The following is a description of a gene set: Genes down-regulated in B lymphocytes: control versus CpG oligodeoxynucleotide 1826. species: Homo sapiens We have previously shown that rheumatoid factors (RF) produced by Fas-deficient autoimmune-prone mice typically bind autologous IgG2a with remarkably low affinity. Nevertheless, B cells representative of this RF population proliferate vigorously in response IgG2a/chromatin immune complexes through a mechanism dependent on the sequential engagement of the BCR and Toll-like receptor 9 (TLR9). To more precisely address the role of both receptors in this response, we analyzed the signaling pathways activated in AM14 B cells stimulated with these complexes. We found that the BCR not only serves to direct the chromatin complex to an internal compartment where it can engage TLR9 but also transmits a suboptimal signal that in combination with the signals emanating from TLR9 leads to NF-kappa-B activation and proliferation. Importantly, engagement of both receptors leads to the upregulation of a group of gene products, not induced by the BCR or TLR9 alone, that include IL-2. These data indicate that autoreactive B cells, stimulated by a combination of BCR and TLR9 ligands, acquire functional properties that may contribute to the activation of additional cells involved in the autoimmune disease process. from publication Busconi L, Bauer JW, Tumang JR, Laws A, Perkins-Mesires K, Tabor AS, Lau C, Corley RB, Rothstein TL, Lund FE, Behrens TW, Marshak-Rothstein A (PMID 18025183) Human Gene Set: GSE6674_UNSTIM_VS_CPG_STIM_BCELL_DN, and this is the list of marker genes: NDE1, IQCE, PHF5A, HIGD2A, BPGM, LMAN1, MPV17, SLC29A1 (solute carrier family 29 member 1 (Augustine blood group)), WBP1, LSS, NME3, ANKRD22 (ankyrin repeat domain 22), QSOX1, FHOD1, ACAD9, S1PR1, NUP37, BEST1, SUSD1, IMP3, MIR302A (microRNA 302a), LRRC45 (NCBI Gene Id 201255), HGSNAT, TRUB2, OLFM4, SLC22A4, FMNL1, CCDC14, SLC37A2, MMACHC, RBM44, PDE2A, ABCD1, SUSD3, HNRNPH1, NAV1, LMBR1, PCDHB18P, ACTR10, CTHRC1, EFL1, ARHGAP27, CGNL1, TALDO1 (NCBI Gene Id 6888), NDUFA12, YTHDF2, SLC4A1AP, HGF, NBEAL2, HSPB6, LSG1, LAT, DNAJC2 (DnaJ heat shock protein family (Hsp40) member C2), B3GNT2, CABYR, SLCO4A1, ANKRD26 (ankyrin repeat domain containing 26), HYCC1, CREG2, SLC48A1, GTF2H5, SFXN4, PRKCH, TMEM266 (NCBI Gene Id 123591), PAF1, POLR3F, UFD1, MOGAT2, INPP5J, AHR, ABT1, HABP4, ENTPD7, SSX2IP, CEP152, ABHD4, BTBD9, RNF128, NADSYN1, GRIPAP1, MEFV, RASGRP4 (RAS guanyl releasing protein 4), FTSJ1, DCUN1D3, KIT, SLC20A1, TOMM7, NUP107, DESI1, NCDN, MTFR1, NPPC, KCTD12, TRA2B, AGK, MRPL49, GPKOW, BACE1, FHL1, SHARPIN, PSMD4, ALDH9A1, MAF, PADI4, BGN, PDXK, IBTK, CBR1, OAS3, LGR4, PCGF2, MIR191, SLC25A35, SUOX, WWOX, PTPRS, PSTK, CCDC163, RNF185, CD300LB, SLC41A3, PECR, MKRN2, DUS4L, DVL1, SLC38A7, ZXDC, TMEM141, PLD3, HIPK1, PLCXD2, S100A10, RIC3, NSMF, RBM38, HSD17B10, CIDEB (NCBI Gene Id 27141), TRPV2, CCK, COPS6, AKAP8L, SHC1 (SHC adaptor protein 1), MAPDA, TTLL12, SDC2, CBLB, H4C3, PNPLA7, GALT, THAP3, POLR1A, TRAF1, TMEM143, PMVK, RNF20, PYCR2, JADE1, ENC1, RO60, TGFBI, RTEL1, HAUS8, RASA3, ALDH1A1